The following is a description of a gene set: A reddish-blue mottled condition of skin caused by inflammation of the cutaneous blood vessels. Livedo species: Homo sapiens Human Gene Set: HP_LIVEDO, and this is the list of marker genes: CBS, MYH11, CDH23, TP53, HLA-DRB1, NR3C1, ADA2, USP8, ATR, ATRX, PDSS1, GUCY1A1, APOLD1, USP48, RECQL, POLE, BTNL2, STING1, BRAF, ACTA2 (NCBI Gene Id 59)